Given this list of marker genes NUP42, EMD, NUP93 (nucleoporin 93), RAE1, NEK7, NUP155, POM121C, LEMD3, NUP62, NUP210, CDK1, PLK1, PRKCB, NUP98, LEMD2, NUP50, NUP205, NUP133, SEH1L, LPIN3, NUP58, TMPO (thymopoietin), LPIN2, BANF1 (NCBI Gene Id 8815), CCNB2, NUP188, POM121, NUP160, LMNB1, LMNA, RANBP2, NDC1, CCNB1, PRKCA, NUP54, SEC13, NUP85, CTDNEP1, LPIN1, AAAS, NUP153, NEK9, NEK6, TPR, NUP37, NUP35, NUP88, NUP107, CNEP1R1, VRK1, VRK2, NUP214, NUP43, here is a description of the gene set: Reactome Pathway: Nuclear Envelope Breakdown studied in species Homo sapiens part of: Mitotic Prophase The nuclear envelope breakdown (NEBD) happens in late prophase of mitosis and involves disassembly of the nuclear pore complex, depolymerization of the nuclear lamina, and clearance of nuclear envelope from chromatin. NEBD allows mitotic spindle microtubules to access condensed chromosomes at kinetochores and enables nuclear division and segregation of genetic material to two daughter cells. For a recent review, please refer to Guttinger et al. 2009.<br><br>In mitotic prophase, chromatin detaches from the nuclear envelope, and this contributes to the nuclear envelope breakdown. VRK1 (and possibly VRK2) mediated phosphorylation of BANF1 (BAF), a protein that simultaneously interacts with DNA, LEM-domain inner nuclear membrane proteins, and lamins is considered to be one of the key steps in the detachment of the nuclear envelope from chromatin.